The following is a description of a gene set: Human Gene Set: PAX4_04 studied in species Homo sapiens Genes having at least one occurrence of the motif RAAAAWTANNNNNNNNNNNNNNNYCACNCC in the regions spanning 4 kb centered on their transcription starting sites. This matches the PAX4 transcription factor binding site V$PAX4_04 (v7.4 TRANSFAC)., and this is the list of marker genes: ACKR1, CLC, PAPPA, C8orf82, NIPBL, NFIB, ARHGAP45, SGTB, CHCHD7, GNAO1, BCL6 (BCL6 transcription repressor), PLPP3, LRRC57, DICER1, RAP2C, PRUNE1, ABLIM1, TIMELESS, HNRNPA0, PURA, RHBDL3, MNT, ABI3BP, LIMS1, EBF2, ZBTB20, UBTF, ITPR3 (inositol 1,4,5-trisphosphate receptor type 3), HOXD9, CCDC177, PHOX2B, ZFHX3, ERF, ROGDI, MTUS1, GSK3B, SF3B5 (NCBI Gene Id 83443), WAPL, POU4F2, MPRIP, SRRM4, VANGL1, CHST11, SLITRK1, RFX3, TCF12, RBMS3, KRT31, DUSP4, GARS1, CDC42EP5, NFIX, OTX2, LUC7L3, PHLDA3, HOXA5, SMARCA1, NHLH2, UBE2B, ITSN1, ARHGAP30, SOX4, SEMA3C, ITIH6, SOCS1, KLHL40, PDZRN4, CALD1, NREP, GRIA3 (glutamate ionotropic receptor AMPA type subunit 3), GET4, NLK, PPOX, HOXB7, TGFB3, EMP1, RGS3, HOXB9, TCF4, AUTS2, SIM1, LMO3, SMAD6, KRTAP17-1, ASXL1, JARID2, CRYZL1, MYO18A, TBCC, KLF9, ELK1, ARID4A, ACMSD, MEIS1, ANKS1B, C12orf50, ITGA3, KLF7, NTRK2, SKIDA1, FOXP2, QRICH1, HOXA9, CCNG1, HAND2, MAP3K11, PDE1A, PIK3C2A, TNRC6A, ARL6IP6, ZBTB18, FOXP1, RAB10, ING3, IKZF2, HOXB4, DSCAM, HLX, MORF4L2, FOXN3, ZMYM2 (NCBI Gene Id 7750), PRRX2, SOBP, CXCR1 (NCBI Gene Id 3577), GAL3ST4, FGF14, ADCYAP1, LIX1L, ERG (ETS transcription factor ERG), IMPDH2, KDM4A, PTPRC, ZNF462, MIR9-1HG, IKZF1, WDPCP, SOX15, NLN (neurolysin), HOXB8, HHIP, EN1, AKAP12, BRINP3, JPH4, GABRA1, EBF1, RBM14, FGGY, PITX2, MPPED2, HAUS2, MEOX2, POU3F3, ANGPT2, WNT2, CHD4, MARCKS, MEF2C, SLC5A3, HOXC11, SOHLH2, ELMO3, C1orf43, PRKAG1, SIX4, ASXL2, CFAP161, USP9X, CEPT1, GPR135, STC1, MRPL48, NEDD4L, ARHGAP36, COL25A1, CCNI, BEND4, STEAP4, ROCK1, CDH10, JDP2, PLXNA2, STAG2, BCL11A, ZNF521, ZEB2, TSSK4, STOML2, FOXP3, TRPM3, NNAT, ARRDC3, MYT1, SUPT16H, MAP2K7, WNT8B, CAMK2D, IGF1R, NKAPP1, DMD, FBXO11, WWP2 (NCBI Gene Id 116013), MYLK, ASB11, RTN3, CRISPLD1, PHF21A, E2F1, SALL3, MINDY1, PPP1R10, MRPS18B, PLAG1, NECAP1, BACH2, LMO4, ENSG00000204117, ETV1, NRAS, CACNG2, CAVIN2, NKX2-2, CNOT2